The following is a description of a gene set: from publication Tabula Muris Consortium (PMID 32669714) Mouse Gene Set: TABULA_MURIS_SENIS_LUNG_B_CELL_AGEING species: Mus musculus, and this is the list of marker genes: Psmb9, Ankrd44, Serpina3g, Ccnd2, H2-Eb1, Jund, Kctd12, Plek, Sp140l1 (NCBI Gene Id 381287), Ptpn1, Tcf4, Pik3r1, Emc7, Sp100, Wasf2, Vcf1, Psmb8, Cd72, AW112010, Napsa, H2-K1, Hspd1, Cd9, Calm2, Tnfaip8, Emp3, H2-Ab1, Srrm2, Tubb4b (NCBI Gene Id 227613), Trappc6b, Malat1, Psme1, Ctsh, Ywhaq, Fxyd5, Ahnak, Sp140l2, Scimp, Ly6a, Gns, Fcgr2b (Fc receptor, IgG, low affinity IIb), Itgb1, Pld4, Lgals3, Atp2b1, Capg, H2-D1, Gpr183, Bcl2a1b, Cd81, Cd2, Jun, Psme2, Man1a, Tpr, Phf11b, Cyba, Zbtb32, B2m, Pura, Aldh2, H2-Aa, Srgn, Sik1, Scgb1a1, Evi2a, Mtdh, Mtss1, Lgals1, Odc1, Prr13, Grb2, Crip1, Neat1, Adgre5, Sp140, Cd44, Vim, Gimap4, Hp1bp3, Itm2b, Anxa6, Ier2